The following is a description of a gene set: The chemical reactions and pathways leading to the formation of tetrapyrroles, natural pigments containing four pyrrole rings joined by one-carbon units linking position 2 of one pyrrole ring to position 5 of the next. Mouse Gene Set: GOBP_TETRAPYRROLE_BIOSYNTHETIC_PROCESS species: Mus musculus, and this is the list of marker genes: Snx3, Ireb2, Urod, Hmbs, Spta1, Hnf1a (HNF1 homeobox A), Abcb10, Srrd, Slc6a9, Ank1, Iba57 (IBA57 homolog, iron-sulfur cluster assembly), Abcb7, Atp5if1, Uros, Abcb6, Sptb, Cpox, Slc25a39, Fech, Slc11a2, Cox15, Tmem14a, Cox10, Ppox, Pgrmc1, Alas1, Alas2, Alad, Rsad1, Tmem14c, Fxn